The following is a description of a gene set: Human Gene Set: HP_ABNORMAL_STERNAL_OSSIFICATION studied in species Homo sapiens Any anomaly in the formation of the bony substance of the sternum. Abnormal sternal ossification, and this is the list of marker genes: FGFRL1, NFIX, CD96, ORC1, LETM1, SOX9, CPLX1, CTBP1, ORC6, VAC14, NSD2 (NCBI Gene Id 7468), FIG4